The following is a description of a gene set: Human Gene Set: WP_TOLLLIKE_RECEPTOR_SIGNALING_RELATED_TO_MYD88 studied in species Homo sapiens Toll-like receptor signaling related to MyD88, and this is the list of marker genes: IRF7, TBK1, IRAK4, TIRAP, TICAM2, REL, IKBKB, NFKB1 (nuclear factor kappa B subunit 1), RELA, TLR7, TICAM1, TOLLIP, TLR6, IKBKE, IRAK1, TLR8, TLR1, TLR5, MYD88, CHUK, IKBKG, TLR3, IRF3, TRAF6, NFKB2, TLR4, TLR2, RELB, TRAF3, MAPK1, TLR9